The following is a description of a gene set: Human Gene Set: HP_CROSSED_FUSED_RENAL_ECTOPIA studied in species Homo sapiens Crossed fused renal ectopia A developmental anomaly in which the kidneys are fused and localized on the same side of the midline. This anomaly is thought to result from disruption of the normal embryologic migration of the kidneys., and this is the list of marker genes: LRP4, SALL4, CTU2, CCNQ, DACT1, EBP, PSMD12, KMT2D, DDX59, APC, KDM6A, CDC42BPB, MNX1, WT1